The following is a description of a gene set: Any process that stops, prevents or reduces the frequency, rate or extent of brown fat cell differentiation. studied in species Mus musculus Mouse Gene Set: GOBP_NEGATIVE_REGULATION_OF_BROWN_FAT_CELL_DIFFERENTIATION, and this is the list of marker genes: Fbn1, Trpv4, Flcn (folliculin), Gata2, Slc7a10